Given this list of marker genes Cyp2j6, Jund, Stub1, Fabp5, Alox8, Lmo3, Asxl1, Ptgis, Bmp2, Cited2, Plin5, Lep, Stard10, Huwe1, Sirt1, Twist1, Asxl2, Paqr3, Alox15, Gps2, here is a description of the gene set: studied in species Mus musculus Any process that modulates the frequency, rate or extent of the peroxisome proliferator activated receptor signaling pathway. Mouse Gene Set: GOBP_REGULATION_OF_PEROXISOME_PROLIFERATOR_ACTIVATED_RECEPTOR_SIGNALING_PATHWAY